The following is a description of a gene set: Genes containing one or more binding sites for (Nr1i2) in their promoter regions (TSS -1000,+100 bp) as identified by GTRD version 20.06 ChIP-seq harmonization. Mouse Gene Set: NR1I2_TARGET_GENES from publication Yevshin I, Sharipov R, Kolmykov S, Kondrakhin Y, Kolpakov F (PMID 30445619) species: Mus musculus, and this is the list of marker genes: Aldh18a1, Gm6712, Syngr4, Prdx5, Oacyl, Lmln (leishmanolysin-like (metallopeptidase M8 family)), Paxbp1, Pcolce2, Gm15335, Ehd1, Tgm2 (NCBI Gene Id 21817), Rmnd1, Plin4, Sfswap, Synj2, Rptor, Gm12295, Ubr2, Slc9a1, B4galt5, Recql, Coq10b, Mia2, Nrbp1, Dph5, Spred1 (NCBI Gene Id 99293), D330050G23Rik, Rapgef3, AU015336, mt-Rnr1, Taf3, Tanc1, C130026L21Rik, Shq1, Glis3, Alkbh3, S100a8, Cspg4b, Naa25, 2610318N02Rik, Kdm5b, Rad51ap1, Gm22294, Tex2 (testis expressed gene 2), Chid1, Slc1a2, Gpr149, Fdxr, Scn3a, Mnat1, 6030442K20Rik (NCBI Gene Id 77876), Mtch1, Mrpl11, Dpp9 (NCBI Gene Id 224897), Zwilch (zwilch kinetochore protein), Slc25a20, Usp2, Il6, Mrpl34, Gtf3c3, Psme1, Gm11475, Sh2b1, Fra10ac1, Blcap, Tmc6, Cers6, Ccdc30, Smim14, 4930449E01Rik, Gm12240, Grpel1, Nup93, G630016G05Rik, Tbc1d1, Vmp1, P3h4, Gm12415, 1700064M15Rik, Cox17, Lox, Plekhn1, Ets1, Hspe1 (NCBI Gene Id 15528), Etv3 (NCBI Gene Id 99611), Hrh1, Skil, Napepld, Dhx38, Mir1960, Cfap43, Gm12796, St6gal1, Zfp521, 2210408F21Rik, 2700049A03Rik, Dcn, Ccnl1, Igf2bp2, Sema3a, Cmbl, Aldh9a1, Nif3l1, Retn, 1700042D02Rik, Proser1, Pcbp1, Pex11g, Tle1, Ecpas, Sec16b, Csf1, Tnks1bp1, Capzb, Rtkn, Tbc1d14, Ptch2, Ccdc18, Map3k8, Ap1g1, Xab2, Psmd6, Mrps10, Gsk3a (glycogen synthase kinase 3 alpha), Vps13d, Pigt, Rpl32-ps, Mir199a-1, Shprh, Caprin1, 2310001K24Rik, Gnb2, Slc25a39, Wbp11, Hnrnpa1l2-ps, Lcn2, Pigm, Prr14l, Nwd1, Tcf4, Sgk1, Tmed2, Rnaseh2a, Pik3ip1, Gm6822, 4933415A04Rik, Angel2, Fap (NCBI Gene Id 14089), Gm10425, Gm15731, Rnf216, Dnaja3, Mlst8, Zbtb20, Polr1b, Cct8, Gm16416, Btbd19 (NCBI Gene Id 78611), Prkra, Sestd1, Pafah2, mt-Co2, Pcnx4, Cenpu, Samhd1, Vegfd, Usp6nl, Mir100hg, Tmem156, Nr1d1, Lce6a, Gm10463, Ighmbp2, Cfap54, Zeb2, Thyn1, Sgf29, Abi1, Gm14052, Gfm2, Misfa, Cma2, 2210406O10Rik, Zhx3, Ptgr2, Tmem192, Rcc2, Gm18303, Tril, Adamts5, Sparc, Zfp35, Tmigd1, Sod3, Lsp1, Col28a1, Hoxaas2, Ctps1, Ppp1r15b, Csnk1a1, Ston1, Hic2, 4930447M23Rik, D6Wsu163e, Gm13857, Fam107b, Stx18, Ndufa4, Zcchc8, Xrcc5, Zfp827, Drg2, Bbof1, Zfp408, Ccdc170, Sphk2, Gm20568, Tbrg1 (NCBI Gene Id 21376), Ubc, Fam50b, Prnp, Katnip, Cd302, Senp1, Ddx41, Popdc2, Stk40, Zfp64, Nedd4, Gm11175, Mir6386, Dda1, Tnpo1, Stam, Pde4d, Pjvk, Ccdc162, D930032P07Rik, Uspl1, Antxr1, Vps4b, mt-Tc, Zfp386, Otulin, Gm27042, Slc30a3, Src, Ifitm2, Septin9, Pde7a, Lockd, Dlgap4, Il23a, Gcnt2, Ints4, Otud7b, Cd80 (CD80 antigen), Klk9, Garin1a, Batf3, Vasn, Eps8, Gm6044 (NCBI Gene Id 595140), Nsmce1, Tnfaip3, Plk3, Mapkapk2, Nme1, Wars1, Serpine1, Frmd8os, Xdh, Qtrt2, Epha1, Pigu, Gm11823, Epo, Meis2, Xpnpep3, Gm16351, Gm15576, Arhgef19, Arhgap24 (NCBI Gene Id 75397), Gm18982, Coq4, Crem, Pan2, Myl12a, Adcy10, Sqor, Ftdc1, 1600020E01Rik, Clcn3, Rrm2, 2700033N17Rik, Kmt5a, Rnmt, Xpo1, Nsun5, Itga6 (integrin alpha 6), Arf4, Gm11357, Camp, Il13ra2, Cops7b, Tnfsf4, Nup214, Tlk2 (NCBI Gene Id 71049, tousled-like kinase 2 (Arabidopsis)), Gm12653, D16Ertd472e, Gm9687, Tob2, Gipc2, Gsto2, Mt2, Etfa (electron transferring flavoprotein, alpha polypeptide), Mir6367, Chmp1a, Armh1, BC085271, Mpv17l2, Gm25897, Nfia, Cept1, Yeats4, Pole3, Hycc2, Pimreg, Atxn2, Gins2, Pakap, Itpr3, Gm7626, Gm4925, Prune1, Fam168a, Galntl5, Parl, Morrbid (NCBI Gene Id 100048565), Pparg, Dpy19l4, Pde4b, Mthfd2l, Arl6ip5, Nnt, Slpi, Acsl1, 4933434M16Rik, Mir1956 (microRNA 1956), Ralgds, Sema4d, Fam193b, Tpra1, Rpl4, 5430435K18Rik (NCBI Gene Id 71357), Lyrm1, Dhrs7, Nucks1, Cdc16, Mt4, Fut10, Gm5614, Gm20033, Cacnb2, Halr1, Procr, Ywhag, Jmjd1c, Gm17501, Pdk1, C1qtnf1, Chpt1, Papola, Pacsin2, Ing4, Pdgfra, Arhgef25, Pla2g15, Mmp8, Slc18b1, Ctnnd1, Ggn, Git2, Rpl7a-ps8, Rps6kc1, Nup35, Runx2os2, Fubp1, 2310040G07Rik, Parp1, Rras, Tyw5, Pmm2, Rhobtb3, Rnf187, Gm28818 (NCBI Gene Id 102632274), Ghr, Vcam1, Ogt, Traf1, Ift56, Gm10754, Gm5335, Cabyr, Gm12503, Gm26080, Anapc5, Mettl5os, Tmco4, Zfp451, Mir7080 (microRNA 7080), Zwint, Ppm1h, Poldip3, Gas1, Fancc, Smarca2, Ube2f, Lsg1, Mocs2, Klhdc10, Prickle2 (NCBI Gene Id 77894), Lrp1, Cdiptos, Mir6406, Rpl34-ps2, Smg6, Rabggtb, Ciao3, Mir677, Ldha, Rpl36a (ribosomal protein L36A), Rcan1, Slc10a6, Trub2, Tln1 (NCBI Gene Id 21894), Alyref2, Ehbp1, Tnrc18, Cox15, Kat7, Tnks2, Ak2, Pnpla2, Rpl37 (NCBI Gene Id 67281), Gm4861, Fgfr1, Rpl9-ps8, Gm12094, Kcnn4, Arpin, Gm15419, Slc39a13, Isy1, Tmem135, Gpr85, Gm11827, Gjb4, Myrfl (myelin regulatory factor-like), Ccdc191 (coiled-coil domain containing 191), Aurkaip1, Casp12, Adcy7, Plec, Steap2, Dcaf1 (DDB1 and CUL4 associated factor 1), Robo3, Dclk1, Junos, Gm26797, Rasa1, Il1rl2, Arhgdib, Gys2, Ino80b, Kitl, 2610005L07Rik, Spata31e2, Alg8, Gramd2b, Cnot1, Mettl5, Mir22hg, Ero1a, Natd1, Poglut2 (NCBI Gene Id 79069), Brd7, Cycs, Enpp5, Baz1b, Hspd1, Rara, Ddc, Inpp1, Gm8000, Gm2453, Panx3, Erc1, Slc7a11 (solute carrier family 7 (cationic amino acid transporter, y+ system), member 11), Smad3, Asb15, Serf2, Anxa2, Cnih4, Them4, Mtf2, 1110002J07Rik, Gm25582, Nenf, Rbks, Tatdn2, Mrpl16, Rbm39, Gm12762 (predicted gene 12762), Adh4, Ptgfr, Snord13, Micall1, Plekhh2, Plekha5, Fam111a, Gm25408, Dedd, Kcnt2 (potassium channel, subfamily T, member 2), Smim13 (NCBI Gene Id 72908), Mthfd2, Lncenc1, Gm10484, Crispld2, Avpi1, Csgalnact2, Gm26535, Tbc1d17, mt-Tp, Cyp4v3, Mmp2, Gm13726, Abcd4, Wdr25, Sat1, Polr2a, Coq3, Fyb1, 2310022A10Rik, Aaas, Serpinb2, Gm12508, Rpl18, Casp4, Ppm1k, Scd1, Tedc2, Tomm40, Atxn2l, Ubox5, Med8, Fbxo4, Prl3c1, Ivd, Bmt2, Pemt, Galnt9 (polypeptide N-acetylgalactosaminyltransferase 9), 1700054A03Rik, Cltc, 4930551L18Rik, Yipf4, Serpine2, Rpl23a, Gm12022, Coq5, Lrp4, Lrp2bp, Sh3bgrl2, Or6k14, Naaa, Eci2, Gm19705, Tpcn2 (NCBI Gene Id 233979), Runx2, Smad6, Rlim, Sh2d6, Rangap1, Trib1, 4933430I17Rik, Gm4754, Gm29346, Slc15a5, Hdac7, Gm4876, Cdipt, Zfp106, Rbbp5, Pla1a, Oxsm, Prg4, Gm14137, Adamtsl5, Akr1b1, 2010003K11Rik, Mxi1, Arhgap26, Aup1, 4931440P22Rik, Tns3, Gm10101, Slc25a25, Lrrc8c, Zfp960 (NCBI Gene Id 449000), Bdkrb1, Nupr1, Map3k7cl, Kdm5a, Ncoa4, Krtap4-25, Tfec, Txnl4b, 1700030C14Rik, Babam2 (BRISC and BRCA1 A complex member 2), Hoxa2, Pet117, Pitpnc1, Mafg, Asf1b, Oit3, Pmpcb, Slfn2, Clock, Ppp1r9b (NCBI Gene Id 217124), Aldh3a1, 4930579G24Rik, Actn4, Cald1, Hif1a, Gm36888, A130048G24Rik, Cacul1, Fam169b, Tmem186, Sptan1, Gm16863, Bach2it1, Tpt1, Selenos, Cfap251, Wnt9b, Ing2, Tns1, Dbp, Vps36, Lasp1, Ido2, Crygn, Gm16276, Klf3, Dcaf10, Ercc6l, Ank1, Raf1, Pus10, mt-Cytb, Ing3, Trpv2, Krt15, 4930505K14Rik, mt-Td, Gm26703, Capg (capping actin protein, gelsolin like), Pga5, Cnot10, Fosl1, Adamts14, Prss22, Atf1, Mdm2, Jade2, Ebf1, 1700123M08Rik, Pcbp2, Ankmy1, Mbnl1, Gm10369, AI597479, Calhm6, Gm5529, Rnf150, Nup153, G430095P16Rik, Gm8357, Card14, Nr1h4, Selenop, Cdkn2aipnl, Gm6420, Gm17196, Kxd1 (NCBI Gene Id 97450), Rab21, Pet100, 4933431K23Rik, Cep120, Prn (NCBI Gene Id 19121), Zbtb43, 2010110K18Rik, B430319H21Rik, Mrps31, Tsc22d3, Itpkb, 2810407A14Rik, Clec2d, Arl8b, Col7a1, Glyat, Sdhaf3, Serpina3n, Ccdc50, Vgll4, Dhx32, Pnrc1, E230016M11Rik, 2700062C07Rik, Degs1, Snx12, Galnt11, St6galnac6 (ST6 (alpha-N-acetyl-neuraminyl-2,3-beta-galactosyl-1,3)-N-acetylgalactosaminide alpha-2,6-sialyltransferase 6), Washc2, Spata6l, Gm29487, Ptpa, Cd47, Gas2, Ptk7, Dhx8, Klf13, Ank3, Eif1ad, 2310043O21Rik, Pfkp, Fam8a1, 1700113A16Rik, Pdha1, Sptssa (serine palmitoyltransferase, small subunit A), N4bp2l2, Gm16251, Ankef1, Gm15742, Gm10603, C1rl, Zc3h12a, Gm20619, A630023A22Rik, Stfa3, Abhd12, A130023I24Rik, Cdk14, Gm13400 (predicted gene 13400), Ankrd40, Slc1a3, Klra2 (NCBI Gene Id 16633), Ppp2r5b, Zfp27, Mir707 (microRNA 707), Gins3, Itsn1, Apon, Tac1, Gm16508, Hoxd3, Hsd17b14, Camkmt, Acot7, 4930558K02Rik, Banp, Zmiz1os1, Xpnpep2, Erp44, Nsa2, Scgb1a1, Irak2, Lars2, Pttg1ip, H4c14, Neurl2, Il6st, Gm5432, Zfp770, Sh3d19, Ambra1, Gm11816, Adgrg5, Snord118, Slc15a4, Atosa, Fbxo24, Immp2l (IMP2 inner mitochondrial membrane peptidase-like (S. cerevisiae)), Gm16116, Or4c12b, Adck2, Smg7, Lyzl6, St3gal2, Aebp2, Wnt1, Thoc6, Mical2, Rcl1, Zfp273 (NCBI Gene Id 212569), Stab2, Slc16a9, D630024D03Rik, Mmgt2, Iqck, Psmd1, Il31ra (interleukin 31 receptor A), 1700074H08Rik, Snai3, Ccdc85b, Akt1s1, Mrtfb, Synpo, Lrrc75a, Vim, Mecom, Prss46, Csde1, Abhd1, Ndrg1, Ptn, Abl2, Clint1, Rhobtb1, Ndufs1, Havcr2, Gm40117, Agxt, Tmem216, Or10ac1, Fam3c, Gm26885, Pdzrn3, Nmnat2, Psmc2, Dgat1, Acox3, Gm11343, Fpgs, Gm12100, Pex7, Spc25, Oxct1as, Cry2, Nepro, Trp63, Gm9828, Ctnnbl1, Htra2, Efcab2, Arhgap11a, Lrrn4cl, Hdhd3, Gm14064, Ugt1a6a, Carmn, 1200007C13Rik, Nav3, Prepl, Fbxo36, Polq, Mus81, Mad1l1, B230307C23Rik, Guf1, Gm11476, Slc26a4, Zfp365, Nlgn2, Uba7, Ints5, Vsir, Gm5475, Isg20 (NCBI Gene Id 80487), Wwox, Rap1b, 3110009E18Rik (NCBI Gene Id 73103), Lpl, Lix1l (Lix1-like), Srgap2, Sh3kbp1, Olr1, Gm15032, Dnmt3l, Celf2, H4c16, Parva, Tead4, Rabgef1 (NCBI Gene Id 56715), Tmem63a, Nr4a1, Gm7882, Orm2, Alkbh7, Gm13470, Nxt2, Tssk6, Csnk1g2, Abraxas1, Mm2pr, Sh3gl1, Ugt1a8, Rsad1, Cct2, Tbc1d19, Fastkd5, 4930412B13Rik, Tor1aip1, Rida, Hoxd4, Tnfsf13 (tumor necrosis factor (ligand) superfamily, member 13), Ptges, Gm15401, Gm9939, Hp, Znfx1, Osbpl9, Pwwp2b, Top2a (NCBI Gene Id 21973), Acly, Tcta, Cdk4, Lipn, Gm36548, Lrrc49, Phf14, Or10aa4-ps1, Slc17a9, Ap5s1, Sec24c, Psmg3, Sfi1, Ccr1 (NCBI Gene Id 12768), Dixdc1, Gad1-ps, Gm15346, Mgat1, Fam135b, Clec16a, Prickle1, Fmc1, Baalc, Ccp110, Rtn4, Adamtsl4, Hif1an, Bicc1 (BicC family RNA binding protein 1), Gm20445, Mterf4, Wdfy1, Fbxo8, Cdca7, Gpsm1, Gm6142, Gm15997, Rpl11, Tradd, Tmbim1, Cfap97, Rnase10 (NCBI Gene Id 75019), Cln8 (CLN8 transmembrane ER and ERGIC protein), Ankrd13a, Polg, Entpd5, Lix1, Taf15, Gm23323, 2900052L18Rik, Mgst1, Sgk2, Hmgb1, Pi4kb, Gm28535, Mrps12, Ogn, Elovl6, Rnf11, Usp12, Gm29257, Nvl, Zfp493, Ccdc174, Aox1, Smim41, Liph, Kcnq1ot1, Hnrnpf, Cfh, Slc25a29, Dcun1d3, Exosc4, Slc33a1, Gm15722, Srpk2, Krt80, Pcca, Has2, Iftap, Zfp62, Aspscr1, Podnl1, Ramp2, Col4a2, Ttc23, Akap13, Gprc5a, Postn, Stx16, Acbd6, Creld1, Gmnn, Dohh, Rbm17, Gm16364, Aco2, Gdpd2, Foxm1, Mdfic, Islr, Lpp, Slc45a4, Fabp4, Stat3, Bpifc, Tiam1, Ptp4a1, Zbed6, Zkscan6, Gm6283, Kdm3a, Htra1 (NCBI Gene Id 56213), Lrtm1, Nf2, Srpx2, Rab3ip, Neil1, Gm16253, Ampd3 (NCBI Gene Id 11717), Nadk, Rps13-ps5, Hsd17b7, Jarid2, Armc2, Mir3971, Mideas, Ubald2, Ndel1, Snx29, Cpt2, Mrpl44, Mrps6, H2az1, Mdm4, Stoml2, Cstpp1, Smarcd2, 9130204K15Rik, Cer1, Trim13, Gm12925, Usp30, Fitm2, Calhm5, Atg10, Ywhah, Echdc3, Rbm25, Dennd1b, Wwp1, Knop1, Sin3a, Cdc25b, Tmem210, Zfand4 (NCBI Gene Id 67492), Armt1, Gm11550, Wnt5b, Utp3, B530045E10Rik, Lpcat3, Ppp2r3a, Hsd11b1, Zfp91, Gm28809, U90926, Rnf4, Cntd1, Slc19a2, Gm29345, Fundc1, Kcnab1, Oga, Kat14, Scd4, Ubald1, Atp1a3, Gm42745, Gm20714, Akap7 (NCBI Gene Id 54213), Hoxd3os1, Sh3tc1, Kng2, Ctdspl2, Snord42a, Mtg1, Zmynd8, Snf8, Mir155, Abcb8, Gm33280, Bnc2, Aicda, Bmi1, Atp6v0c, Serpinf1, Ist1, Psen2, Oxnad1, Ergic1, Rcc1, Gm22203, Gm8307, Cc2d2a, Medag, Rhoq, Trp53rka, Ctsa, Gm15441, Gm12711, Gm11714, Gm6410, Gm15564, Gramd4, Acaca, Htra3, Eif3f, Plekhb1, Agk, Gm37359 (predicted gene, 37359), Laptm4a, Mmp1b, 9330111N05Rik, Bdnf, Pam, Nfkbiz, Strn3, Rpl5, Mfsd4b3-ps, Agtpbp1, Shc1, Myo1h, Foxred2, Slc35e3, Gprin3, 3110099E03Rik, 5830432E09Rik, Atg7, Tmem109, Apod, Rpl27a-ps1, Ostm1, 1700041I07Rik, Gm2895, Rtn3, Ugdh, AI480526, Tsku, Iba57, Bmf, Tmem256, Camk2d, Caprin2, Cdhr17, Tnni3k, Nr2f6, Gm35299, Psmc1 (NCBI Gene Id 19179), Ciao2b, Ppil3, Ggta1, Rpl36, Wdr36, Man2c1, Mir22, Slc29a1, Slc9a8, Vkorc1l1 (vitamin K epoxide reductase complex, subunit 1-like 1), Neat1, E330011M16Rik, Mir21c, Litaf, Arhgap1, Osmr, Cipc, Bmx, Nsfl1c, Tnfaip2, Ccl9, Camkk2, Enpp3, Magi2, Lamc2, Ints1, Fmn2, Sos2, Fas, Dus1l, Acbd4, Gm25663, Pum3, Lrrc40, Celf1, Ptgs2, St13, Mast4, Tpst1, Kalrn, Gtf2a1, Slc1a5, Zc3h11a, Gm29018, Prdx6, Gm15337, Ltbp3, Slc43a2, Eif3b, Hcar2, Smim10l1, Gm34176, Aifm2, Mir6236 (NCBI Gene Id 102465959), Ddx20, Cdca7l, Mindy1, Wls, 1700082M22Rik, Got2, Plin2, Ppa1, P2ry10b, Gm6077, Ldhb, Gm23119, Gm19088, Zdhhc5, Tm4sf1, Slit2, Sertad4, 6030469F06Rik, Acaa2, Sec61bl, Zfp133-ps, Arl1, Efr3a, Gm36535, Eln, Adtrp, Tbc1d13, Gm7008, Fkbp10, Tmcc1, Tnk2, Zbtb40, Adh5, Ap4e1, Arl14ep, Tyw1, Phip, Inpp5f, Gm20605, Echs1, 9530034A14Rik, Heatr5a, Lrch4, Lta4h, Gm8883, Frat2, Ifrd1, Ptchd4, Scarna17, Mix23, Hcfc1r1, 5930403N24Rik, Chd1, Limk2, Cpeb3, Adcy6, Pidd1, Gm24433, Zbp1 (NCBI Gene Id 80562), Gm13836, Cstf2t, Alad, Zfp426, Wdtc1, D830013O20Rik, Gm13593, Il4ra, Fus, Mbtps2, Gm24253, Gm9831, Ddx56, Gm31728, Yju2b, Rbm28, Smurf1, Gm16288, Gpat3, Ugt1a6b, Gm13489, Snora73a, Vapa, Gins1, Tcirg1, Mlycd, Marcks, Fam32a, Has2os, Rac1, Mmp19, Pex13, Mmp27, Thap6, Ptgs1, Gm12273, Tmem218, Clca4b, Nudt9, Caap1, Tada1, Trpc4ap, Mrps18c, D530037P16Rik, Mcf2l, Snx15, Atp5f1b, Mir1938, Limch1, Ankle1, Atp5mg, Arrb1 (NCBI Gene Id 74110), Epb41l1, Fktn, Mapkbp1, Tmem242, Atp5mc3, Gas7, Cask, Tlr8, Crat, Usp18, Ablim1, Sod2, Crebzf, Cdc25c, Gm13551, Arid1a, Aff1 (NCBI Gene Id 57071), Ccsap, Gm15737, Eif4g1, Trem2, Bach2os, Commd1, Enthd1, Ins2, Cpne3, Ilvbl, Abca1, Akr1c18, Zfp607b, Gm26626, Prl6a1, Trip12, 1700028E10Rik (NCBI Gene Id 69463), Mri1, Hexim2 (NCBI Gene Id 71059), Ccng2, Eef1b2, 2310039H08Rik, Gm27252, Cblb (Casitas B-lineage lymphoma b), Egln2, Kpna1, Tnfaip6, Serpina3f, Zc3hc1, Dbr1, Map3k19, Zfp691 (NCBI Gene Id 195522), Tpd52l2, Cwf19l2, BC028471, Crtc2, Alkbh3os1, Mir6516, Cbfa2t2, Snhg3, Fermt2, Dnajc5, Il33 (NCBI Gene Id 77125), Mgst2, Mrpl21, Malat1, Gm28926, Ndufb3, Capn10, Tbce, Pi16, Mrpl1, Gtpbp1, Met, C3, Gm12602, Fancl, Pard3, Bloc1s5, Tlcd3b, Gm5444, Gm9929, Phlpp1, Gm15413, A230001M10Rik (RIKEN cDNA A230001M10 gene), Dbi, Hoxa3, Emp1, Herc4, Abcd2, Tuba1c, Cep44, Dse, Gm16548, Btf3l4, Fis1, Cacna1g, Erap1, Slc7a7, Socs2, Thrap3, Ptgs2os, Fdx1, Rarg, Hexim1, Gbp2, Ppip5k2, Lgalsl, Agbl5, Cryge, Krt13, Mrfap1, Zfp385b, Ubn2, Gramd1a, Lsm4, Qsox1, Vnn3, Acat2, Gm4890 (NCBI Gene Id 234479), Ltbp1, Gm25558, Marchf7, Trp53inp2, Sun1, Sgms1, Zfp326, 5930430L01Rik, Snd1, Tmem253, Ugt1a7c (UDP glucuronosyltransferase 1 family, polypeptide A7C), Rps15a-ps5, Slfn5, Cyb561, Gm11736, Gm10309, Trim16, Foxp1, Gm12153, Vps50, Sumf1, Tmem258, A730049H05Rik, Chek1, Sp3, Susd1, Tmbim4, Rps26, Apbb2, Usp3, Abca4, Spen, Rnh1, Bcl6, Uck2, Abhd11, Plpp3, Rps3a1 (NCBI Gene Id 20091), Hepacam2, 4933407I08Rik (RIKEN cDNA 4933407I08 gene), Usp54, Gpat4, Rasa3, Csf3, Tchp, Lhfpl2, Mannr, Mir6907, Col27a1, Stn1, Ttll11, Gm24524, Ephb3, Ube2i (NCBI Gene Id 76085), Gm11520, Oxsr1, Akt2, Kcnk10, Mob4, Atf6, Tmem143, Mfsd13a, Slc37a3, Arhgap23, Orm1, Pdss1, Zfp948, Cavin2, Psmf1, Bcl10, Gosr1, Gm10614, Eif4e, Gm25336, Steap4, Gm40332, Prelid2, Il1rl1, Gm13662, 3110031N09Rik, Nuf2, Pdzd9, Etv5, Sox9, 2310005E17Rik, Kat2b, Nbea, Pate1, Pepd, 1700018L02Rik, Mlip, Snrnp200, Ppil2, Helq, Creb5, Adgra3 (NCBI Gene Id 70693), Map3k6, Dicer1, Oas1f, Cd2bp2, Tmcc3, Bbx, Elmod3, Mtif3, Acsl3, Fndc7, Cemip, Vwa8, 4930580E04Rik, Mir5122, Rnu11, Gm7171, Gm12727, Gpr35, Fstl1, 3300005D01Rik, C030010L15Rik, Shroom3, Xrcc6, mt-Tf, 4933404I11Rik, Tacc2, B130034C11Rik, Mtarc1, Gm9889, Cdk5rap1, Dtx4, Gm17057, Alg9, Ndufa5, Ccnt1, Gm25861, Elmod2, 1810024B03Rik, Snord4a, Tbk1, Rab28, Zfp248, mt-Tv, Pmvk, Ndufc2, Foxn2, Sdc4, Emx2, Ado, Ccnd3, mt-Ty, Sh3glb1, Nufip2, Gpr15lg, Heg1, Vps51, Mir6346, Tmem164, Snx21, Zbtb11os1, Knl1, Pcolce, Bms1, Tg, Serpina3h, A930018P22Rik, Cwc22, Snhg20, Mtss2, Fcf1, Eya1, Tgfbrap1, Bin1, Gpr107, Prkce, Gm18800, Nhlrc3, Dhrs9 (dehydrogenase/reductase 9), Gm14221, Por, Ppdpf, Bbox1, Ndufs7, Slc39a14, Surf1, Zzef1, 2310008N11Rik (RIKEN cDNA 2310008N11 gene), Angpt1, Trp53rkb, Ech1, Rufy1, Hnrnpul1, Slc35d1, Tnc, Ticam1, Mars1, Hal, S100a6, 2810405F17Rik, A230028O05Rik, Siglec1, Ncald, Pfdn4, Ndufaf1, Gm10441, Nfe2, A530020G20Rik, Gm13924, Slc39a3, Cab39, Hsf2bp, Pcyt1b, Tti2, Lexis1, Itgb5, C530043K16Rik, Noc3l, Pvt1, Mir6950, Chka, Etfb, Dnajc2, Epb41l3, Morn2, Spty2d1, Tfap2a, Rnase2a, Prkg2, Calm3, Nxn, Spred2, Txndc5, Gapdh, Gm5641, Nelfb, Spp1, Med23 (NCBI Gene Id 70208), Ptgs2os2, Fen1, 2700099C18Rik (RIKEN cDNA 2700099C18 gene), Dusp19, Sncaip, BC049715, Banf1, Dusp11, Gpx1, Igfbp4 (insulin-like growth factor binding protein 4), Srrd (SRR1 domain containing), Hnrnpl, Prxl2a, Map2k6, Uqcc3, Bivm, Pnpla8, Gnas, Duoxa1, Aknad1, Txndc12, Chic2, Il1r1, Sacm1l